The following is a description of a gene set: from publication Chen Y, Wang X (PMID 31504780) species: Homo sapiens Genes predicted to be targets of miRBase v22 microRNA hsa-miR-4766-3p in miRDB v6.0 with MirTarget v4 prediction scores > 80 (high confidence targets). Human Gene Set: MIR4766_3P, and this is the list of marker genes: TP53TG3, CRISPLD1, CCDC80, TTC28, YTHDC1 (NCBI Gene Id 91746), HS6ST3, DGAT2, FRS2, SERPINB5, NDNF, PCDHA1, PSMD7, STRN3, APPBP2, PLCH1, RAP1GAP2, RAD1, PCDHA2, FBXW11, PCDHA9, ADAM28, PCDHA10, PCDHA11, MEMO1, PPIL4, SMARCAD1, YIPF5, CREG2, MRPS30, TAF4, KRT6B, CSNK1D, ACOX1, HERC3, MBTD1, DNHD1, ANKRD44, MLF1, TP53TG3D, NR2E1, SCN3A, ARHGAP17, VAPA, MACIR, SLCO3A1, LRBA, CAMTA1, ZBTB38, SWAP70, IL2RA, PCDHA4, PCDHA12, SLC35F1, AK6, BNIP2, GIMAP8 (NCBI Gene Id 155038), RNF130, IL17RB, DKK2, TGFB2, LCLAT1, NR2F2, KLF8, PPIP5K2, PKP4, PCDHA8, DCN, ZNF425, ARHGAP5 (NCBI Gene Id 394), MYOG, VEGFA, SEC23B, VPS36, FAM3C, PCDHAC1 (protocadherin alpha subfamily C, 1), ZIC4 (Zic family member 4), ZNF2, TRIM43, B3GALT2 (beta-1,3-galactosyltransferase 2), MCMDC2, DNER, USP46, TRIM43B, RNF24, CNN3, ENAH, LAMP1, CALCR, ETV3L, CPEB2, LRRC40, MAG, ANKIB1, SCN8A (sodium voltage-gated channel alpha subunit 8), NR4A3, COL19A1, INTU, MEX3C, TMEM144, OSMR, PCDHA13, DUSP19, GPR37, DERA, IKZF4, CAP2, PCDHA3, CWC27, ANK2 (ankyrin 2), ABCD3, DUXA, TP53TG3B, RAB31, FNDC1, ZFAND1, TCF21, RANBP3L, MARCKS, PCDHAC2, HNRNPA0, RUNX2 (RUNX family transcription factor 2), FSIP1, SRRM1, DNAJA4, C15orf40, DOCK7, PCDHA7, OTOGL, CENPK, TRIM16, EHF, EXOC8, CCDC190, RIMKLB, HNRNPD, FAF2, DIP2C, UBAP1, HERPUD1, SEMA3E, SRGAP2C, MED6, GCG, SIPA1L1, ZPLD1, CNOT4, KTN1, PCDHA5, ZCCHC3, PCDHA6 (NCBI Gene Id 56142), IREB2, SC5D, LARP1B, SRGAP2B, CDK6, PCLO, PHF13, COX15, FUT9, TRIM16L